Given this list of marker genes TPI1 (triosephosphate isomerase 1), PSTPIP1, NAIP, TRIO, CD1D, RAB31, IFITM2, LIMS1, ANXA2P1, SERPINB6, PPIF, IFITM3, ID2, DHRS3, CLEC4A, IRAK3, FGR, CLIC2, ALDH3A2, CIITA, CD33, LST1, LIMK1, ICAM3 (intercellular adhesion molecule 3), PID1, CD1C, ITGB2, AOAH, CNN2, LGALS1, FGL2, FCGR2A, DOCK5, PPM1F, TNFAIP2, CSF1R (NCBI Gene Id 8156), PICALM, SH3BP2, ZFP36L1, ANXA5, ACSL5, TMEM123, PILRA, LINC00115, OAS3, CEBPB, PLAAT4, IL1R2, CSRP1, FYN, MNDA, LYST, SEC14L1, ITGAX, GMFG (glia maturation factor gamma), BTF3, PSTPIP2, CLEC7A, S100A10, TLR2, YBX3, COL9A2, CIDEB, EPB41L2, APLP2, TCEAL4, MARCKS, CST7, TUBA4A, CEBPD, TST, TIMP1, RNH1, LGALS9, BASP1, SEC11A, ADAM28, SLC35D2, SAT1, APOL3, ASAH1, ANXA2P2, SERPINA1, SGK1, SEMA4A, MEGF9, LAT2, VCAN, SLC2A3 (solute carrier family 2 member 3), KCTD12, PLXNC1, KLF11, GDI2, AIF1, FZD1, LMNA, GAS7, PIK3CB, RGS10, RHOG, APOL1, COTL1, RAB32, LDHA, SMS, AKR1B1, CASP1, CDKN1B, ACTG1, CD86, PTGS1, IL18 (NCBI Gene Id 3606), LY86, PDLIM1, MFNG, CFP, NIBAN1, NLRP3, RCBTB2, ATP2B1, ADAM8, EGR1, EVL, MAGEF1, FCN1, MSN, EVI2A, CNIH4, ATP1B1, ENTPD1, NDRG2, HK2, CTSH, PTGER4 (NCBI Gene Id 5734), RBPJ, TBL1X, ANXA2 (annexin A2), MTHFD2, CD1B, P2RY13, PADI2, RTN1, ACTN1, QPCT, CD163, TUBA1A, IFI30, MTMR11, NACC2, FLNA, S100A4, PPA1, LGALS3, PFN1, ATG3, DOK2, RIN3, PRCP, ANXA1, CLEC10A, GAPDH, HLA-DRA, C2CD2, EMP3, C11orf21, ARHGAP45, AHR, SAP30 (Sin3A associated protein 30), BCL6, ITGA5, FCGR2C, ITGB7, ELOVL5, CSTA, PLBD1, SIRPA, EFHD2, ARRB1, APOBR, IGSF6, CACNA2D3 (calcium voltage-gated channel auxiliary subunit alpha2delta 3), CKLF, EIF4EBP2, PTP4A2 (protein tyrosine phosphatase 4A2), AGTPBP1, IL1RN, VDAC1, DPYD, ATP8B4 (ATPase phospholipid transporting 8B4 (putative)), APAF1, NCF2, CRYBG1, GSE1, HCK, CST3, ASAP1, CD1E, RGCC, PAK1, IL1B, here is a description of the gene set: Human Gene Set: GSE29618_PDC_VS_MDC_DAY7_FLU_VACCINE_DN Systems vaccinology has emerged as an interdisciplinary field that combines systems wide measurements and network and predictive modeling applied to vaccinology. Here we used the systems vaccinology approach to study the molecular mechanisms underlying th studied in species Homo sapiens Genes down-regulated in comparison of plasmacytoid dendritic cells (DC) from influenza vaccinee at day 7 post-vaccination versus myeloid DCs at day 7 post-vaccination. from publication Nakaya HI, Wrammert J, Lee EK, Racioppi L, Marie-Kunze S, Haining WN, Means AR, Kasturi SP, Khan N, Li GM, McCausland M, Kanchan V, Kokko KE, Li S, Elbein R, Mehta AK, Aderem A, Subbarao K, Ahmed R, Pulendran B (PMID 21743478)